The following is a description of a gene set: studied in species Homo sapiens Human Gene Set: MAP2K1_TARGET_GENES Genes containing one or more binding sites for (MAP2K1) in their promoter regions (TSS -1000,+100 bp) as identified by GTRD version 20.06 ChIP-seq harmonization. from publication Yevshin I, Sharipov R, Kolmykov S, Kondrakhin Y, Kolpakov F (PMID 30445619), and this is the list of marker genes: H2BC11, PKM, GAS5, SGK1, MAT2A, HOOK2, MALAT1, MIR5087, FOS